Given this list of marker genes SOCS2, GAN, PDE8A, ZFX, TET1, C11orf24, FOXG1, LACTB, KCNJ3, PRAMEF14, SFRP2, FNIP2, SIM1, EIF4E, PDS5B, ZNF98, NSG1, ELAVL2 (ELAV like RNA binding protein 2), JADE1, PLXNC1, LIN54, CCDC6, RREB1, NRG4, IBSP, ARHGAP29, NFAT5, DMRTA2, RUFY3, FNDC3B, ZSWIM6, DDX3X, PLPPR4, PTPRJ, DLG3 (discs large MAGUK scaffold protein 3), DAAM1, NRF1, DUSP18, ZFHX4, RAB21, ASPHD2, MTDH, HERC2, RP2, HNRNPA0, ATL1, ADAMTS17, CAMK4, SRGAP2C, KCNA1, KCNK10, SAMD12, NWD2, GPM6A, PPP2R2C, NKX2-3, PRAMEF2, KBTBD2, NRG1, CDK6, PRRC2B, SCN1A, ZNF711, PRAMEF13, GJB5, TNPO1, ZNF469, RAB14 (NCBI Gene Id 51730), ADAMTSL3, BEND6, UBE2Z, MACIR (NCBI Gene Id 90355), DOCK4, UCHL3, PPP4R1, USP36, CSMD1, FBXW7, TNRC6B, OTULIN, CNNM3, ABTB3, here is a description of the gene set: Human Gene Set: MIR500A_3P from publication Chen Y, Wang X (PMID 31504780) Genes predicted to be targets of miRBase v22 microRNA hsa-miR-500a-3p in miRDB v6.0 with MirTarget v4 prediction scores > 80 (high confidence targets). species: Homo sapiens